The following is a description of a gene set: Mouse Gene Set: GOBP_NEGATIVE_REGULATION_OF_CELLULAR_RESPONSE_TO_OXIDATIVE_STRESS Any process that stops, prevents or reduces the frequency, rate or extent of cellular response to oxidative stress. studied in species Mus musculus, and this is the list of marker genes: Meak7, Tldc2, Oxr1, Rnf146, Reg3b, Tbc1d24, Scly, Ncoa7, Tsc1, Hspb1